Given this list of marker genes GDF6, MORN5, GRIA1, SLC22A11, UNC5B, USP6NL, PTPRG, CHSY3, FHIP2A, FAM76B, C14orf119, here is a description of the gene set: from publication Chen Y, Wang X (PMID 31504780) Human Gene Set: MIR6854_3P Genes predicted to be targets of miRBase v22 microRNA hsa-miR-6854-3p in miRDB v6.0 with MirTarget v4 prediction scores > 80 (high confidence targets). species: Homo sapiens